Given this list of marker genes SLC28A1, SLC22A2, SLC28A3, SLC29A2, SLC29A3, SLC29A1, SLC22A1, SLC28A2, here is a description of the gene set: studied in species Homo sapiens Enables the transfer of a pyrimidine nucleoside, a pyrimidine base covalently bonded to a ribose or deoxyribose sugar from one side of a membrane to the other. Human Gene Set: GOMF_PYRIMIDINE_NUCLEOSIDE_TRANSMEMBRANE_TRANSPORTER_ACTIVITY